The following is a description of a gene set: Endothelial cells are known to be a rich source of transcriptional gene expression. Recent technological advances now permit the detailed profiling of mRNA expression using arrays of known cDNAs on blots. We have used such arrays to examine expression of mRNA by primary isolates of human foreskin microvascular endothelial cells in the proliferative and quiescent state. Cells were stimulated by a combination of known growth factors for these cells including epidermal growth factor (EGF), vascular endothelial growth factor (VEGF), and 'endothelial cell growth supplement (ECGS)' either alone or in combination. Analysis showed the expression of many mRNAs but of the 588 examined, only one, namely monocyte chemotactic protein-1 (MCP-1), showed a decrease on treatment with EGF. A combination of image grabbing followed by subtractive densitometry enabled identification of the mRNAs upregulated in proliferating endothelium. In consideration of the possibility of selective vascular targeting, of particular interest was the increase in expression of the mRNA for the cell surface proteins vascular endothelial (VE-) and neural (N-) cadherin and alpha5, alphav, beta1 and beta3 integrins. The alpha5 integrin offers a previously unrecognized opportunity for vascular targeting. Genes up-regulated in HDMEC cells (microvascular endothelium): proliferating vs quiescent cells. from publication Zhang HT, Gorn M, Smith K, Graham AP, Lau KK, Bicknell R (PMID 14517420) Human Gene Set: ZHANG_PROLIFERATING_VS_QUIESCENT studied in species Homo sapiens, and this is the list of marker genes: MAP3K11, BAX, CCNB1, MCAM, NME2, DDIT3, HSP90AA1, GSTM1, ITGAV, JUN, DYNLL1, CCNG2, CCND1, DAD1, GPX1, PRDX2, ITGB3, CCN2, TIE1, ITGA6, GSTP1, TEK, AXL, CXCL8, CCND2, RELA, CASP4, TMSB10, RAD23B, CXCL2, CASP3, RPS19, RPL6, GPI, NDUFB7, MDM2, GRB2, ELOC, PLAUR, GNAS, ITGA5, IGFBP2, MARCKSL1, RHOA, GADD45A, SKI, HSPB1, PTMA, CDH2